Given this list of marker genes Grp, Rbm10, Dnmt1 (NCBI Gene Id 13433), Gapdhrt2, Adcy10, Stk4, Gapdhrt, Slc7a5, Gapdh, Pdcd4, Agtr1a, Mfn2, E2f3, Pparg, Mir124a-1hg, Sod2 (superoxide dismutase 2, mitochondrial), Atf4, Igf1, Cftr, here is a description of the gene set: Mouse Gene Set: GOBP_VASCULAR_ASSOCIATED_SMOOTH_MUSCLE_CELL_APOPTOTIC_PROCESS species: Mus musculus Any apoptotic process in a vascular associated smooth muscle cell.